Given this list of marker genes Mfap2, Alms1, Hoxc10, Elovl3 (NCBI Gene Id 12686), Esrrg, Stat6, Ucp2, Ccr2, Nova1 (NOVA alternative splicing regulator 1), Hcrt, Smarca4, Ksr2, Pwwp2b, Cav1, Ednrb, Adrb3, Apln, Cmklr1, Ybx2, Acadl, Tfe3, Pparg (peroxisome proliferator activated receptor gamma), Mup11, Sirt6, Slc25a44, Ptger3, Lep, Fabp4, Oxt, Slc27a1, Pdgfc, Trpv2, Egr1, Adrb2, Adipor2, Il18, Ptges, Adipoq, Zbtb7b, Hadh, Letmd1, Gatm, Mup2, Fto, Acsl1 (acyl-CoA synthetase long-chain family member 1), Acvr2b, Zfp423, Igf2bp2, Acot11, Npr3, Cxcr4, Mup1, Abhd6, Arrdc3, Cd36, Irf4, Edn2, Cidea, Zfp516, Gimap5, Epas1, Kdm6b, Ffar4, Kdm3a, Cpt2, Tnf, Il1a, Cebpb, Nr1h3, Lama4, Prlr, Plac8, Ache, Adora1, Plcl2, Dbh, Nr1d1, Sqstm1, Syk, Ghrl (ghrelin), Ip6k1, Mfn2, Rheb, Foxc2, Pctp, Gja1, Fgf21, Apc, Prkab1, Hdac3, Ppargc1b, Mcrip2, Scd1, Oma1, Ebf2, Trpv1, Alpl, Tshr, Per2, Fh1, Abat, Mup3, Thra, Stk11, Igf1r (NCBI Gene Id 77773), Dync1h1, Mc3r, Kdm1a, Lgr4, Notch1, Trpm2, Ces1d, Gadd45g, Ucp1, Ccl5, Dhrs7b, Dio2, Cckar, Il1rn, Adcyap1, Mup5, Fcor, Nova2, Plcl1, Lnpep, Tle3, Pth2r, Atf4, Bscl2, Htr2a, Rb1, Drd2, Map2k6, Il4ra, Clstn3, Adipor1, Nmu, Gnas, Drd1, Napepld, Ptgs2, Stat3, Nr1h2, Gpr3, Gimap3, Jak2, G0s2, Sfxn5, Appl2, Pgam5, Rbpj, Cnr1, Actn3, Mup4, Adam17, Id1 (NCBI Gene Id 98917), Lcn2, Ddit3, Ppargc1a, Gpx2, Il15, Nod2, Prdm16, Tlr4, Aldh1a1, Nox3, Wnt10b, Sln (NCBI Gene Id 66402), Adamts5, Adrb1, Il13, Acot13, Elovl6, Prkab2, Ntsr1, Phox2b, Lpin1, Acadvl, Atf2, Tnfrsf11a, Il4, Vegfa, Dock7, Gpx1, Il18r1 (interleukin 18 receptor 1), Ogt, Tnfsf11, Nrdc, Il1b, Fabp5, Cnot3, Grb10, Decr1, Hsf1, Trpm8, Pemt, Ccr5, Bmal1, Oxtr, Lepr, Ehmt1, Qki, Flcn, here is a description of the gene set: studied in species Mus musculus Mouse Gene Set: GOBP_TEMPERATURE_HOMEOSTASIS A homeostatic process in which an organism modulates its internal body temperature.